Given this list of marker genes Rasef, Slc15a5, Csn2, Mmd, Slc6a1, Golga1, Evi5, Plg, Nup107, Pappa2, N6amt1, Cdyl2, Dusp8, Trpa1, Zdhhc9, Ugt8a, Spink11, Lin54, Map2, Yy2, 1110004F10Rik, Fbxl17, Sema3e, Zfp867, 9330159F19Rik, Sgcg, Oat, Tra2b, Kics2, Ric1, Tafa2, Ocrl, Gucy1a2, Csgalnact2, Srsf5, Slc6a20b, Homer1 (homer scaffolding protein 1), Abca8b, Fgl2, Arid2, Dmd, Prdm1, Pde4b, Mob4, Smr2l, Peli1, Setd2, Zfhx4, Pikfyve, Hao1, Fezf1, Csf3r, Dlgap1, Zdhhc17, Jade1 (NCBI Gene Id 99826), Suv39h2 (NCBI Gene Id 99049), Zfp423, Fut9, Srpk2, Myo9a, Tjp1, Prrc2c, Gnb2 (NCBI Gene Id 14693), Ltn1, Rassf5, Cebpb, Smad6, Golim4, Wbp4, Adnp, Gtpbp1, Prim1, Eya1, Cep350 (centrosomal protein 350), Zfp711, Prkca, Hes1, Pnrc1, Zswim6, Ptpn12, Hps3, Ltbp1, Ino80d, Zfr, Inhbb, Dr1, Wsb1, Rimoc1, Adcy5, Tdo2, Erc1, Tle4, Gpr17, Spag9, Rfx4, Tead3, Shisa6, Sema3d, Dlg3, Tut4, Pou4f1, Nipa2, Relch, Kat6a, Ythdf2, Kif20a, Cemip, B230219D22Rik, Ceacam1, Fbxo30, Mlx, Sez6, Zpbp, Spag7, Parp8, Tmem47, Rai1, Mbnl2, Rc3h1, Fnip1, Egr1, Ankrd50, Dyrk1a, Gopc, Desi1, Adgrl2, Syt1, Ntf3, Thbd, Maip1, Vegfc, Elovl5, Ncbp2, Mgat4a, Braf, Chd7, Zfp236, Slc39a12, Cdh2, Agtr1b, Rnf38, Zfp37, Trim23, Elmod1, Tmem196, Prkg1, Ttpal, Zmynd8, Ep300, Ppp1r2, Nipbl, Fam135a, Ncoa2, Zfp281, Atp11c, Adamts6, Cask, Gsk3b, Dennd5a, Zhx1, Numbl, Ube2e2, Rab11fip2, Foxo1, Nop58, Nox1, Glrb, Ranbp9, Tnrc6a, Cebpa, Mroh5, Sp3, Rap1b, Osbpl11, Fgd6 (FYVE, RhoGEF and PH domain containing 6), Lypla1 (lysophospholipase 1), Il12a, Fancf, Trappc8, Med13 (NCBI Gene Id 68851), Ccdc88a, Afg3l2, Bace1, Zfand5, Efna5, Rgs7bp, Sirt1, Asb3, Pttg1ip, Zeb1, Adam10, Abr, Ythdf1, Pals1, Ube3a, Dipk2a, Arl2bp, Gbx2, Ccdc82, Rnf214, Cux1, Plk4, Plxna2, Tbx4, Hoxb3, Itgb2, Agk, Mylk4, Anln, Aff3, Lig4, Uchl3, Arid4a, Rbm41, Plekha7, Ttbk2, Trp53inp1, Ccne2, P2ry10b, Ap1s3, Nkx2-2 (NCBI Gene Id 228734), Plat, Akap7, Bicd2, Fzd5, here is a description of the gene set: Mouse Gene Set: MIR_369_3P Genes predicted to be targets of miRBase v22 microRNA mmu_miR_369_3p in miRDB v6.0 with MirTarget v4 prediction scores > 80 (high confidence targets). studied in species Mus musculus from publication Chen Y, Wang X (PMID 31504780)